The following is a description of a gene set: Human Gene Set: MCCABE_HOXC6_TARGETS_CANCER_DN from publication McCabe CD, Spyropoulos DD, Martin D, Moreno CS (PMID 18339881) species: Homo sapiens Homeobox transcription factors are developmentally regulated genes that play crucial roles in tissue patterning. Homeobox C6 (HOXC6) is overexpressed in prostate cancers and correlated with cancer progression, but the downstream targets of HOXC6 are largely unknown. We have performed genome-wide localization analysis to identify promoters bound by HOXC6 in prostate cancer cells. This analysis identified 468 reproducibly bound promoters whose associated genes are involved in functions such as cell proliferation and apoptosis. We have complemented these data with expression profiling of prostates from mice with homozygous disruption of the Hoxc6 gene to identify 31 direct regulatory target genes of HOXC6. We show that HOXC6 directly regulates expression of bone morphogenic protein 7, fibroblast growth factor receptor 2, insulin-like growth factor binding protein 3, and platelet-derived growth factor receptor alpha (PDGFRA) in prostate cells and indirectly influences the Notch and Wnt signaling pathways in vivo. We further show that inhibition of PDGFRA reduces proliferation of prostate cancer cells, and that overexpression of HOXC6 can overcome the effects of PDGFRA inhibition. HOXC6 regulates genes with both oncogenic and tumor suppressor activities as well as several genes such as CD44 that are important for prostate branching morphogenesis and metastasis to the bone microenvironment. Genes whose promoters were bound by HOXC6 in LNCaP cells (prostate cancer) and which were down-regulated in comparison of tumor vs normal prostate tissue samples., and this is the list of marker genes: MKKS, SPTLC2, TBC1D9, PAK2 (NCBI Gene Id 9106), PLCB3, ARIH1, OGFOD1, GTF2H3 (NCBI Gene Id 2967), ERRFI1, PAWR, TSEN34, PDS5B, IGFBP3, AP1M2, PIEZO1, RAB9A, PSEN1, SRP14 (signal recognition particle 14), CHCHD5 (NCBI Gene Id 84269), MRPL52